The following is a description of a gene set: studied in species Homo sapiens An intracellular signaling cassette that starts with production of cyclic AMP (cAMP), and ends with activation of downstream effectors that further transmit the signal within the cell. Human Gene Set: GOBP_CAMP_MEDIATED_SIGNALING, and this is the list of marker genes: PDE3B, PDE6A, PDE8A, APLNR, RAPGEF2, CAP2, PDE1B, PDE7A, PDE3A, NRXN1, CGAS (cyclic GMP-AMP synthase), PDE8B, PDE5A, PDE6B, PDE10A, PDE4B, PDE4A, PDE9A, PDE4C, PDE11A, PDE2A, PDE4D, PDE1A, TOR2A, PDE6C, CAP1, C14orf28, PDE7B, PDE1C